The following is a description of a gene set: Mouse Gene Set: GOMF_PHOSPHOLIPASE_D_ACTIVITY Catalysis of the reaction: a phosphatidylcholine + H2O = choline + a phosphatidate. studied in species Mus musculus, and this is the list of marker genes: Pld6, Enpp2, Arf4, Pld4, Gpld1, Arf1 (NCBI Gene Id 11840), Pld1, Arl1, Pld2, Pld3, Hmox1